Given this list of marker genes Iscu, Fxn, Sdhb, Sdhaf1, Lyrm4, Dld, Mdh2, Trap1, Sdhaf3, Sdhaf2 (succinate dehydrogenase complex assembly factor 2), Idh3g, Isca1 (NCBI Gene Id 69046), Idh2, Fh1, Dlst, Mrps36, here is a description of the gene set: electronically inferred by orthology from the curated human pathway part of: Aerobic respiration and respiratory electron transport This event has been computationally inferred from an event that has been demonstrated in another species.<p>The inference is based on the homology mapping from PANTHER. Briefly, reactions for which all involved PhysicalEntities (in input, output and catalyst) have a mapped orthologue/paralogue (for complexes at least 75% of components must have a mapping) are inferred to the other species. Reactome Pathway: Citric acid cycle (TCA cycle) studied in species Mus musculus